The following is a description of a gene set: studied in species Homo sapiens Human Gene Set: GOMF_EXOGENOUS_PROTEIN_BINDING Binding to a protein or protein complex from a different species, for example a pathogen molecule binding to a host protein., and this is the list of marker genes: EPHA2, CD86, SLC20A2, NECTIN2, TYRO3, XPR1, SCARB2, SLC3A2, LAMP1, MOG, HSPA1B, TNFRSF14, CLEC4M, F11R, CDK1, SLC7A1, DPP4, ITGA5, ACE2, AXL, IDE, NECTIN4, SLC52A1, HTR2A, TNFRSF4, HYAL2, HYAL3, LDLR, TFRC, CD209, NPC1, HAVCR1, CR1, CLDN1, CD46, DAG1 (dystroglycan 1), RPSA, ITGB1, ALB, CLEC5A, ITGB5, ITGB3, HYAL1, ICAM1 (NCBI Gene Id 3383), CCR5, NCAM1, SCARB1, CD81, MYH9, EFNB3, CD80, MYH10, MRC1, EFNB2, ITGAV, PLSCR1, ITGA2, CLDN9, CXCR4, CLDN6, SLAMF1, SLC1A5, EGFR, SERPINB3, SLC52A2, CR2, ANPEP, ITGB7, CD55, SLC10A1, CLEC4G, GPR15, CDHR3, CXADR, PVR, HSPA1A, NECTIN1, CD4, GYPA, ITGB6, ILF3, SELPLG, SIVA1, BSG